The following is a description of a gene set: Mouse Gene Set: GOBP_REGULATION_OF_SYSTEMIC_ARTERIAL_BLOOD_PRESSURE_MEDIATED_BY_A_CHEMICAL_SIGNAL studied in species Mus musculus The regulation of blood pressure mediated by biochemical signaling: hormonal, autocrine or paracrine., and this is the list of marker genes: Edn1, Edn3, Agtr2, Adra1a, Adra1b, Mme, Drd3, Comt (NCBI Gene Id 319399), Nr3c2, Serpinf2, Mcpt4, Agt, Kcnn4, Ace, F2rl1, Chrm3, Sucnr1, Ndst2 (N-deacetylase/N-sulfotransferase (heparan glucosaminyl) 2), Avpr1a, Anpep, Nkx2-1, Sod2, Cyp2j5, Adrb3, Cpa3 (NCBI Gene Id 12873), Prep, Ednrb, Ace2, Enpep (glutamyl aminopeptidase), Slc2a5, Ren1, Rhoa, Adrb2, Ece1, Tacr1, Prcp, G6pdx, Atp6ap2, Nox1, Cyba, Agtr1a, Gja5, Rps6ka2, Oxtr, Agtr1b, Rasl10b, F2r, Or51e2, Adra1d, Corin, Drd5, Ace3, Avpr2, Hsd11b2, Adrb1, Tpm1, Avpr1b, Edn2, Klk1b26, Mrgprd, Nos3, Mas1, Cyp11b2